Given this list of marker genes PIK3CA, MIR30C1, MTMR2, DGKG, MBOAT7, MTMR7, VAC14, PIP5K1B, SLC27A1, PIGT, APOA2, LPIN1, MTMR14 (NCBI Gene Id 64419), INPP5K, PIK3CB, AGPAT5 (NCBI Gene Id 55326), MOGAT2, DGKI, PTEN, INPP5J, MTMR4, PIP4K2A, LPGAT1, PCK1, CTDNEP1, DGKD, ACP6, CRLS1 (NCBI Gene Id 54675), PIK3C2B, MTM1, CWH43, PITPNM3, PIP5K1A, ITPKB, PGAP4, PIGC, PIP5K1C, MPPE1, UVRAG, FABP5, PLIN5, MIR29B1, PIGK, SLC30A5 (NCBI Gene Id 79021), DGKH, SH3YL1, IP6K3, PIGZ, LDLR, DGKQ (NCBI Gene Id 1609), SLC44A4, LIPH, PIK3CG (NCBI Gene Id 5294), CEPT1, SYNJ2, BECN1, GPAT4, PGAP1, LPIN2, SCARB1, PIPSL, HDHD5, INPP4A, PIK3C3 (NCBI Gene Id 5289), PI4KAP2, MTMR3, HYCC2, PNPLA3, SH3GLB1, ABHD5, IMPA1, GNPAT, TMEM68, PTDSS2, PI4K2B, PIGX, MTMR6, FAR1, ABHD8, LPIN3, PLD2, PIP4K2C, PI4KB, TPTE2, AGPAT4, PIGL, RAB38, DGKA, PCYT1A, C3, PLCE1, ETNK2, ACSL3, SACM1L, CHPT1, MTMR1, DPM2, INPP4B, PGS1, ACSL1, GK, AWAT2 (NCBI Gene Id 158835), AGPAT3, PNPLA2, MFSD2A (MFSD2 lysolipid transporter A, lysophospholipid), PIGB, INPPL1, DGAT2, PIGP, PIGH, LPCAT1, PIGM, TMEM150A, PIP4K2B, EFR3A, ABHD3, GPAM (NCBI Gene Id 57678), TTC7B, PTPRQ, NR1H3, PI4K2A, LCAT, CDS1, PLA2G4A, PLA2G15, EFR3B, CDIPT, HTR2A, PIGF, PCYT1B, BMX, PIGG, PISD, IP6K1, PIKFYVE, PCYT2, CAPN2, DGKK, OCRL, PCK2, DGKE, FABP3, PEMT, TMX1, ETNK1, THRSP, CHKB, AGPAT2, BPNT1, INPP5E, PIGY (NCBI Gene Id 84992), PIGV, ALOX15, SLC44A2, HTR2C, DAGLA, DAGLB, PITPNM1, CDS2 (NCBI Gene Id 96708), HTR2B, IP6K2, PIGQ, PLA2G4C, DPM1, CHAT, DGKB, IMPA2, GPAT3, HYCC1, MOGAT1, LPCAT3, PLSCR1, LIPI, DPM3, FIG4, SIK1, INPP5F, AJUBA, PGAP2, DGKZ, PDGFA, SLC44A5, PIGW, PITPNM2, PIK3R1, PIK3R4, NR1H4, LPCAT4, ITPKC, ITPKA, PGAP3, PIGU, LCLAT1, PIGS, CHKA, PTDSS1, KAT5, CNEP1R1, MIR548P, INPP1, GPLD1, DGAT1, PIK3C2G, PIGA, SLC44A1, AVIL, CLN3, MOGAT3, PTPMT1, PIK3CD, PIGO, AGPAT1, TTC7A, PIP5KL1, PDGFB, SREBF1, SELENOI, SYNJ1, TAMM41, ATG14, DGAT2L6 (diacylglycerol O-acyltransferase 2 like 6), AGMO, NR1H2, PLD1, APOA1, PIK3C2A, PLCG2, FBXW7, ABHD4, SMG1 (SMG1 nonsense mediated mRNA decay associated PI3K related kinase), ATM, GPAT2, PIGN, GPAA1, PI4KA, INPP5D, PIK3R3, SIRT1, BPNT2, SLC44A3, LPCAT2 (lysophosphatidylcholine acyltransferase 2), here is a description of the gene set: species: Homo sapiens The chemical reactions and pathways resulting in the formation of glycerolipids, any lipid with a glycerol backbone. Human Gene Set: GOBP_GLYCEROLIPID_BIOSYNTHETIC_PROCESS